The following is a description of a gene set: Human Gene Set: REACTOME_RUNX1_INTERACTS_WITH_CO_FACTORS_WHOSE_PRECISE_EFFECT_ON_RUNX1_TARGETS_IS_NOT_KNOWN species: Homo sapiens RUNX1 interacts with co-factors whose precise effect on RUNX1 targets is not known, and this is the list of marker genes: EP300, YAF2, BMI1, ARID2, PHC3, PCGF5, SMARCD1, CBX2, CBX8, CBFB, SMARCD2, SCMH1, PBRM1, HIPK2, SMARCC1, SMARCC2, SMARCA2, RYBP, CBX6, RNF2, CSNK2A2, SMARCE1, SMARCB1, RING1 (ring finger protein 1), CBX4, SMARCA4, ACTL6A, RUNX1, ARID1A, CSNK2B, ACTL6B, PHC1, AUTS2, SMARCD3, CSNK2A1, PHC2, ARID1B